Given this list of marker genes C3orf70, NXNL2, RBM39, RPN2, ERBIN, SFMBT2, MAEL, IRS2, TMEM17, GLB1, MOB3B, B4GALT1, POGZ, CMTM3, RAB3IL1, OSBPL1A, SLC5A9, FOXK1, RNASE4, CPOX, NGRN, RAB18, L3HYPDH, IL4R, ZKSCAN3, TOX2, TMEFF1, B3GNT8, PDE3B, TNK2, P2RY10, S1PR3, RNF149, EHMT1, NPR3 (natriuretic peptide receptor 3), SEMA3D, BAP1, MED14, ADGRL2, NRIP3, NR1D2, MATR3, ARHGAP28, FYCO1, PIGL, ETS1, ITGB7, GPR45, EBF4, MYOF, TRMT1, FAM209A, CAMSAP2, LINC00511, PROS1, MACIR, PDPN, STON1, RPL9 (ribosomal protein L9), LRRC8C, AP5M1, SALL4, STXBP5, FARP2, ARHGAP18, PRR12, IPO5, STK17B (serine/threonine kinase 17b), SPATA1, TGFBR1, PIK3CG, SMURF1, FBXO44, PTK2, BTG1, GAMT (guanidinoacetate N-methyltransferase), GAB2, GASK1B, IRF8, ZNF467, GDF3, RIN2, GOLM1, GJA5, RELL1, NCMAP, DNTT, STIM2, GPSM2, ZFP90, SMAD1, GBA2, ADAM15, ACSBG1, PANK1, SMAD4, SDC4, FURIN, AHRR, FAM184B, DAND5, B4GALT3, CD8A, RSRP1 (arginine and serine rich protein 1), VANGL2, ZBTB2, ITGB4, ATP13A5, TSSK1B, PDE4DIP, ZNF287, PPP1R16B, PRNP, KYNU, CTSW (cathepsin W), RNF130, ENDOD1, ABI3, TCF4, DNAJB14, CUTC, FADS1, ZNF318, RBPJ, N4BP1, IPO7, ZNF687, FRY (NCBI Gene Id 404759), BPNT1, RAD52, GIPR, HTR1F, EXOC7 (exocyst complex component 7), ZBTB8B, FNDC3A, AMZ1, RGMB, RNF39 (ring finger protein 39), SIAE, CLASP2, FUT8, IL6ST, INHA, CFAP90, KCTD6, CYP1B1, DUSP22, MAF, SH2D4B (NCBI Gene Id 407974), EPB41L2, LCE3B (late cornified envelope 3B), TMEM207, FANCI, MYO5A, HBP1, CP (ceruloplasmin), ZNF692, GABARAPL1, ALPG, CAPN2, CAPG, HTT, TMEM176B, PRSS27, GPR146, GLCE, ALG2, FBXL21P, CXCL11, FAM20A, FLNA, CTSF, LPAR6, DDI2, CD38, ST6GALNAC1, IYD, ATRAID, EIF2AK4, APBA1, MYO16, TMEM176A, EPB41L1, EMX2, SELPLG, MSMB, SCN3B, SEPTIN6, SERAC1, TRAPPC10, KCNA6, CRTC3, DDX5, TRHDE (thyrotropin releasing hormone degrading enzyme), RSPO3, ERBB2, CDK6, IL9, SEPTIN10, here is a description of the gene set: Bone marrow-derived macrophages were produced from mice lacking IL-10 alone (IL10-def) or mice lacking both IL-10 and the p50/p105 subunit of NF-kB (p50/IL10), and left unstimulated, stimulated with LPS (1 ng/ml) or stimulated with LPS and IL-10 (0.3 ng/ml). Genes up-regulated in NFKB1 and IL10 knockout macrophages stimulated by LPS versus those also stimulated by IL10. Human Gene Set: GSE19941_LPS_VS_LPS_AND_IL10_STIM_IL10_KO_NFKBP50_KO_MACROPHAGE_UP from publication Yang HT, Wang Y, Zhao X, Demissie E, Papoutsopoulou S, Mambole A, O'Garra A, Tomczak MF, Erdman SE, Fox JG, Ley SC, Horwitz BH (PMID 21217011) studied in species Homo sapiens